The following is a description of a gene set: studied in species Homo sapiens from publication Lund R, Aittokallio T, Nevalainen O, Lahesmaa R (PMID 14607935) Human Gene Set: GSE2770_IL12_VS_IL4_TREATED_ACT_CD4_TCELL_2H_UP Th1 and Th2 cells arise from a common precursor cell in response to triggering through the TCR and cytokine receptors for IL-12 or IL-4. This leads to activation of complex signaling pathways, which are not known in detail. Disturbances in the balance between type 1 and type 2 responses can lead to certain immune-mediated diseases. Thus, it is important to understand how Th1 and Th2 cells are generated. To clarify the mechanisms as to how IL-12 and IL-4 induce Th1 and Th2 differentiation and how TGF-beta can inhibit this process, we have used oligonucleotide arrays to examine the early polarization of Th1 and Th2 cells in the presence and absence of TGF-beta after 0, 2, 6 and 48 hours of polarization. Genes up-regulated in CD4 T cells activated by anti-CD3 and anti-CD28: IL-12 (2h) versus IL4 (2h)., and this is the list of marker genes: DTWD2, LAYN, DPY19L4 (dpy-19 like 4), GLG1 (golgi glycoprotein 1), TOGARAM1, KLHL28, COX16, COASY, GOLT1B, LPAR1, KRTAP10-10, LMO4, LRWD1, CATSPER4, KBTBD7, CEBPZ, FAR2, LARP1B, ARPP19, CREBL2, CDH10, EXOC3, DBF4, DIDO1, CRB3, SLC22A25, LUC7L2, CAMSAP1, CHMP1B, H1-2, KCMF1, DENND6A, ITGA8, DUSP14, MCUR1, EIF4EBP1, CCDC88A, PIEZO1, LAP3, FUT8, FOXO1, B3GLCT, CNPY4, HEXA, KCNV2, GOLM2, CTTNBP2NL, KHDRBS1, LPAR5, CPE, BMP15, COMMD2, ZNF729 (NCBI Gene Id 440517), FANCD2, ING3, DPY19L3, CAMTA1, CRBN, ITIH4, FIG4, EIF4EBP2, DCAF10, H1-1, CCDC141 (coiled-coil domain containing 141), GRK2, GRAMD2B, FOXD4, HHIPL2, ERAL1, ARL8B, ABCD2, KTI12, E2F8, HTRA1, DIMT1 (NCBI Gene Id 27292), ARMCX1, GAP43, C2orf49, ANKS6, ECH1, FAM107A, GPR151, IDH3G, CMTM3, GPKOW, FBXO11, ITGA2B, ANKK1, CEP83, ALG2, ALDH6A1, FAM222A, DOCK4, CAPRIN1, ATP6V0E1, CERS5, ACP1, KLHL7 (kelch like family member 7), ATP6V1D, CETN2, CALCRL, FNDC4, BDKRB2 (bradykinin receptor B2), CXCL3, ARF4, FPGT, ATP6V0C, FANCC, EIF4A1, EREG, CLUAP1, GRPEL2, IL23R, GAREM1, ALG12, CEACAM19, COMMD3, ATG2B, C1orf54, MIS18BP1, NOP53, MIA2, LAPTM4A, CDC40, FBXO9 (F-box protein 9), CDK13, HDAC3, ZNG1A, EXOC3L1, HACL1, ACAN (aggrecan), ERH, CORO6, FNIP1, ASZ1, EIF3B, ARNT, JAK2, ECSIT, LAMP1, CHURC1, KPNA7, BGN, DDB1, CACHD1, CFL1, FBXO48